The following is a description of a gene set: Punctate opacification of the cornea Human Gene Set: HP_PUNCTATE_OPACIFICATION_OF_THE_CORNEA Punctate opacification (reduced transparency) of the corneal stroma. studied in species Homo sapiens, and this is the list of marker genes: UBIAD1, CHST6, KRT12, CYP4V2, PSMB8